The following is a description of a gene set: The series of molecular signals initiated by interleukin-27 binding to a receptor on the surface of a target cell, and ending with the regulation of a downstream cellular process, e.g. transcription. Human Gene Set: GOBP_INTERLEUKIN_27_MEDIATED_SIGNALING_PATHWAY species: Homo sapiens, and this is the list of marker genes: IL27RA, OASL, IL6ST, OAS3, MX1, STAT1, OAS1, OAS2